The following is a description of a gene set: Any process that modulates the frequency, rate or extent of protein localization to cell-cell junction. Mouse Gene Set: GOBP_REGULATION_OF_PROTEIN_LOCALIZATION_TO_CELL_CELL_JUNCTION studied in species Mus musculus, and this is the list of marker genes: Vcl, Dsg2, Ctnnd1, Pecam1, Dsg3, Zdhhc7